Given this list of marker genes GRIN1, GRID2IP, STXBP1, PLXNA4, GNB5, GNAO1, CBLN1, GRID2, TMEM240, GPM6A, SHANK1, SYNDIG1, GRIA1, C1QL2, ITGB1, SLC17A6 (NCBI Gene Id 57084), SLC16A7, UNC13C, CACNG3, SYP, BSN, NLGN4Y, NETO1, CHD4, NLGN1, AKAP5, ADCY8, CALB2, SRPX2, ATP2B3, LRRC4, ELFN1, SHISA7, PALLD (NCBI Gene Id 51653), SHISA6, YWHAH, C1QL1, KCNJ9, GRIA2, CNTN6, SYT1, SLC6A9, PPP3R1, SYT11, GIT1, PDE4B, SLC17A8, ADGRB3, CTNNA2, KCNJ3, LRRTM2, NLGN2, FGFR2, DLG4, ITGA3, BAIAP2, CADPS2, GRIA3, PLXNC1, GRN, CBLN3, P2RX6, SORT1, NLGN3, SPTBN2, NLGN4X, SUSD4, SLC17A7, here is a description of the gene set: Human Gene Set: GOCC_EXCITATORY_SYNAPSE species: Homo sapiens A synapse in which an action potential in the presynaptic cell increases the probability of an action potential occurring in the postsynaptic cell.